Given this list of marker genes Dld, Mrps36, Dlst, here is a description of the gene set: species: Mus musculus electronically inferred by orthology from the curated human pathway Reactome Pathway: OGDH complex synthesizes succinyl-CoA from 2-OG part of: Citric acid cycle (TCA cycle) This event has been computationally inferred from an event that has been demonstrated in another species.<p>The inference is based on the homology mapping from PANTHER. Briefly, reactions for which all involved PhysicalEntities (in input, output and catalyst) have a mapped orthologue/paralogue (for complexes at least 75% of components must have a mapping) are inferred to the other species.